Given this list of marker genes GRIP1, DVL1, MFSD2A, MAP3K13, NTNG2, MYO9A, MACF1, FZD4, MOV10, DLG4, SPRY3, DVL3, DVL2, NTNG1, WNT5A, here is a description of the gene set: studied in species Homo sapiens Human Gene Set: GOBP_REGULATION_OF_NEURON_PROJECTION_ARBORIZATION Any process that modulates the frequency, rate or extent of the process in which the anatomical structures of a neuron projection are generated and organized into branches.